The following is a description of a gene set: Human Gene Set: GOBP_POSITIVE_REGULATION_OF_PROTEIN_UBIQUITINATION species: Homo sapiens Any process that activates or increases the frequency, rate or extent of the addition of ubiquitin groups to a protein., and this is the list of marker genes: RNF180, NPM1, CRY1, MAGEA2, WFS1, FBXO4 (F-box protein 4), SKP2, LRRK2, UBE2L3, FBXW7, PRICKLE1, BTRC, BIRC2, TICAM1, CDK5RAP3, BMI1, AMER1, CUL3, FBXO33, SPHK1, AXIN1, PHF23, GABARAP, CDC20, MYCBP2, PSMD10, INAVA, COMMD1, CENPS, SKP1, BIRC7, NDFIP1, UBE2V1, STUB1, RBX1, HUWE1, DDX3X, FZR1, RNF111, PAXIP1, PTPN22, CENPX, XIAP, WBP1L, UBE2N, CBLB, MAGEA2B, MAPK9, MALT1, GSK3A, PELI1 (pellino E3 ubiquitin protein ligase 1), RCHY1, DNAJB2, MTA1 (metastasis associated 1), RIPK2, UBE2V2, PLK1, NSMCE3 (NCBI Gene Id 56160), BIRC3, HSPA5, CAV1, BIRC8, UBE2D1, HSPBP1, RASSF1, BCL10, PTTG1IP, AIMP2, UBE2S, UBB, TRAF6 (NCBI Gene Id 7189), UBQLN1, UBE2C, GSK3B, SPRTN, RPS2, ARRDC3, HAMP, ANGPT1, ARRDC4, TSPYL5, FANCM, TRIB3, KDM1A, TBC1D7, PDCD6, SENP2, RASSF5 (NCBI Gene Id 83593), NHLRC1, DERL1, KLHL40, FANCI, HDAC3, PINK1 (PTEN induced kinase 1), DNAJA3, MAGEC2, CDC14B, NOD2, UBE3A, SEPTIN4, PEF1, MARCHF7, CHFR, PRKN, SPSB4, FAM107A (family with sequence similarity 107 member A), LAPTM5, NMI, NGF, NDFIP2